Given this list of marker genes Lhx1, Pkd2, Wt1, Bmp4, Pax8 (NCBI Gene Id 18510), here is a description of the gene set: studied in species Mus musculus The process in which the metanephric S-shaped body is generated and organized. The metanephric S-shaped body is the successor of the metanephric comma-shaped body that contributes to the morphogenesis of a nephron in the metanephros. Mouse Gene Set: GOBP_METANEPHRIC_S_SHAPED_BODY_MORPHOGENESIS